The following is a description of a gene set: Protrusion of the meninges and portions of the spinal cord through a defect of the vertebral column. Myelomeningocele studied in species Homo sapiens Human Gene Set: HP_MYELOMENINGOCELE, and this is the list of marker genes: PORCN, ZIC3, CCL2, SNRPB, DRG1, FLNA, IGF2, GLI3, TBXT, PIK3CA, MSX2, KCNQ1OT1, FUZ, SIN3A (SIN3 transcription regulator family member A), H19 (NCBI Gene Id 14955), BMPER, FREM2, GRIP1, OFD1, PAX3, VANGL2, VANGL1, HES7, DACT1, ARPC4, FRAS1, ALX4